Given this list of marker genes IL2, LCK, IL2RG, IL2RB (NCBI Gene Id 3602), JAK3, STAT5A, IL2RA, JAK1, STAT5B, PTK2B (protein tyrosine kinase 2 beta), SHC1 (NCBI Gene Id 6464), SYK, here is a description of the gene set: Reactome Pathway: Interleukin-2 signaling part of: Interleukin-2 family signaling Interleukin-2 (IL-2) is a cytokine that is produced by T cells in response to antigen stimulation. Originally, IL-2 was discovered because of its potent growth factor activity on activated T cells in vitro and was therefore named 'T cell growth factor' (TCGF). However, the generation of IL-2- and IL-2 receptor-deficient mice revealed that IL-2 also plays a regulatory role in the immune system by suppressing autoimmune responses. Two main mechanisms have been identified that explain this suppressive function: (1) IL-2 sensitizes activated T cells for activation-induced cell death (AICD) and (2) IL-2 is critical for the survival and function of regulatory T cells (Tregs), which possess potent immunosuppressive properties.<br><br>IL-2 signaling occurs when IL-2 binds to the heterotrimeric high-affinity IL-2 receptor (IL-2R), which consists of alpha, beta and gamma chains. The IL-2R was identified in 1981 via radiolabeled ligand binding. The IL-2R alpha chain was identified in 1982 (Leonard et al.), the beta chain in 1986/7 and the IL-2R gamma chain in 1992 (Takeshita et al.). The high affinity of IL-2 binding to the IL-2R is created by a very rapid association rate to the IL-2R alpha chain, combined with a much slower dissociation rate contributed by the combination of the IL-2R beta and gamma chains (Wang & Smith 1987). After antigen stimulation, T cells upregulate the high-affinity IL-2R alpha chain; IL-2R alpha captures IL-2 and this complex then associates with the constitutively expressed IL-2R beta and gamma chains. The IL-2R gamma chain is shared by several other members of the cytokine receptor superfamily including IL-4, IL-7, IL-9, IL-15 and IL-21 receptors, and consequently is often referred to as the Common gamma chain (Gamma-c). The tyrosine kinases Jak1 and Jak3, which are constitutively associated with IL-2R beta and Gamma-c respectively, are activated resulting in phosphorylation of three critical tyrosine residues in the IL-2R beta cytoplasmic tail. These phosphorylated residues enable recruitment of the adaptor molecule Shc, activating the MAPK and PI3K pathways, and the transcription factor STAT5. After phosphorylation, STAT5 forms dimers that translocate to the nucleus and initiate gene expression. While STAT5 activation is critical for IL-2 function in most cell types, the contribution of the PI3K/Akt pathway differs between distinct T cell subsets. In Tregs for example, PI3K/Akt is not involved in IL-2 signaling and this may explain some of the different functional outcomes of IL-2 signaling in Tregs vs. effector T cells. studied in species Homo sapiens